Given this list of marker genes NANS, GNE, NANP (N-acetylneuraminic acid phosphatase), CMAHP, CMAS, SLC35A1, here is a description of the gene set: The chemical reactions and pathways involving CMP-N-acetylneuraminate, a substance composed of 5-(acetylamino)-3,5-dideoxy-D-glycero-D-galacto-non-3-ulosonic acid in glycosidic linkage with cytidine monophosphate. Human Gene Set: GOBP_CMP_N_ACETYLNEURAMINATE_METABOLIC_PROCESS species: Homo sapiens